Given this list of marker genes H3C4, H4C1, H3C3, H3C6, H4C5, H3C13, H4C3, H4C14, KDM1B, H3C15, PHF2, H4C2, KDM5C, KDM4B, KDM6B, KDM5A, H4C12, RIOX2, H4C16, H3C7, H3C12, KDM3B, H4C13, H3C8, H4C9, H4C6, KDM2B, KDM2A, ARID5B, KDM4D, H4C4, KDM3A, UTY, H3C11, PHF8 (PHD finger protein 8), KDM5B, KDM4C, JMJD6, H3C1 (NCBI Gene Id 8350), KDM1A, H4C11, H3C2, KDM4A, H3C10, KDM5D, KDM7A, H4C8, H4C15, KDM6A, H3C14, here is a description of the gene set: Human Gene Set: REACTOME_HDMS_DEMETHYLATE_HISTONES studied in species Homo sapiens HDMs demethylate histones